Given this list of marker genes CPM, OXTR, ALDH1L2, KRT15, TIMP2, CDH16, ADCY5, KRT4, KRT19, DPP4, CPA4, CST2, OLFML2A, PSG5, here is a description of the gene set: Human Gene Set: BLANCO_MELO_COVID19_SARS_COV_2_LOW_MOI_INFECTION_A594_ACE2_EXPRESSING_CELLS_DN studied in species Homo sapiens Analysis of the transcriptional response to SARS-CoV-2 compared with other respiratory viruses, including MERS-CoV, SARS-CoV-1 (SARS), human parainfluenza virus 3 (HPIV3), respiratory syncytial virus (RSV), and IAV. Genes down-regulated in SARS-CoV-2 low MOI infection (ACE2 expressing A549 cells, MOI: 0.2, 24hpi) from publication Blanco-Melo D, Nilsson-Payant BE, Liu WC, Uhl S, Hoagland D, Møller R, Jordan TX, Oishi K, Panis M, Sachs D, Wang TT, Schwartz RE, Lim JK, Albrecht RA, tenOever BR (PMID 32416070)